Given this list of marker genes Lpo, here is a description of the gene set: This event has been computationally inferred from an event that has been demonstrated in another species.<p>The inference is based on the homology mapping from PANTHER. Briefly, reactions for which all involved PhysicalEntities (in input, output and catalyst) have a mapped orthologue/paralogue (for complexes at least 75% of components must have a mapping) are inferred to the other species. part of: ROS and RNS production in phagocytes electronically inferred by orthology from the curated human pathway studied in species Mus musculus Reactome Pathway: Events associated with phagocytolytic activity of PMN cells